Given this list of marker genes EMC4, STIP1, NDUFA4, ECT2, GTF2I, VAMP3, FIRRM, EPDR1, PSMA5, GPR160, SLC44A3, PSMG1, PBK, S100A10, UQCRFS1, CLNS1A, HSP90AB1, TPRKB, CCNDBP1, SEC61A1, YBX1, RACK1, CD46, GFM2, C1QBP, DCUN1D5, SLC39A6, CTNNAL1, PSMD8, FBXO10, MRPL42, MCTS1, MORN2, SEC23B, ARPC1A (NCBI Gene Id 10552), SCAMP3, TPX2, LSM2, ATF1, SKIC8, RNASEH2A, XRN2, UBE2T, SLC29A1, DCTN3, ADH5, IMPA2 (inositol monophosphatase 2), XRCC5, POLE2, PGD, STOML2, H2BC9, FKBP11, COPA, LAMTOR5, PSMC3, CCT4, FCER1G, PPP2R3C, CIAO2A, TPD52L1 (TPD52 like 1), MANF, TYROBP, HSPA13, MSH2, MRPS12, PRPS1, PSMD10, SPOPL, TM9SF2, HAT1, COPS3 (COP9 signalosome subunit 3), RFC3, PIGF, RFC4, GMNN (NCBI Gene Id 51053), SNX7, MRPL13, EBPL, HAUS1, H2AZ1, G3BP2, MAD2L2, RAN, SNRPD1, UBE2E3, NUP37, TP53RK, GLUD2, DPCD, ATIC (5-aminoimidazole-4-carboxamide ribonucleotide formyltransferase/IMP cyclohydrolase), SNHG29, PPIL1, SELENOT, HNRNPA0, RFC5, ME2, PDIA6, SLC25A5, NUDT21, CITED2, CAPZA2, CCT2, MRPS23, YAP1, MRPL39, NEU1, GJA1, MMGT1, TMEM50A, CNN3, RAD51AP1, DNAJA1, PSMA2 (proteasome 20S subunit alpha 2), RPS16, WDR83OS, DBI, FUCA2, CDK1, SMIM26, ABHD6, LYZ, STT3A, NFYC, ZNHIT3, CDK4, LYSET, ALG13, HIKESHI, MRPL44, APOO, POLE3, MED21, MAGED1, CAB39, ATP1A1, NUP205, TMX1, AQP11, PRMT6, WARS1, SEC11A, ACTR6, RNF141, RHOA, MAD2L1, RPS10P5, WDSUB1, RPL7A, RPA3, RAE1, TMBIM4 (NCBI Gene Id 51643), BAG2, ABCB10, CHCHD2, CENPH, TYMS, NONO, BAX, CDKN3, TAB2, CCNB2, PGK1, SNRPD2, DNAJB9, DPM1 (dolichyl-phosphate mannosyltransferase subunit 1, catalytic), FCGR3A, VBP1, OSTC, E2F5, MAPRE1, PCNA, HSPA8, C1GALT1C1, FARSA, SYPL1, FEN1 (flap structure-specific endonuclease 1), FUNDC1, ALDOA, WASHC5, RCN2, VDAC3, CMAS, ILF2, SNX2, GNAI1, TSPAN6, UXT, PRDX4, ATP6V0D1, METTL13, DAD1, ATG3, PRKAB1, here is a description of the gene set: from publication Chiang DY, Villanueva A, Hoshida Y, Peix J, Newell P, Minguez B, LeBlanc AC, Donovan DJ, Thung SN, Solé M, Tovar V, Alsinet C, Ramos AH, Barretina J, Roayaie S, Schwartz M, Waxman S, Bruix J, Mazzaferro V, Ligon AH, Najfeld V, Friedman SL, Sellers WR, Meyerson M, Llovet JM (PMID 18701503) Marker genes down-regulated in the 'unannotated' subclass of hepatocellular carcinoma (HCC) samples. Human Gene Set: CHIANG_LIVER_CANCER_SUBCLASS_UNANNOTATED_DN Hepatocellular carcinomas represent the third leading cause of cancer-related deaths worldwide. The vast majority of cases arise in the context of chronic liver injury due to hepatitis B virus or hepatitis C virus infection. To identify genetic mechanisms of hepatocarcinogenesis, we characterized copy number alterations and gene expression profiles from the same set of tumors associated with hepatitis C virus. Most tumors harbored 1q gain, 8q gain, or 8p loss, with occasional alterations in 13 additional chromosome arms. In addition to amplifications at 11q13 in 6 of 103 tumors, 4 tumors harbored focal gains at 6p21 incorporating vascular endothelial growth factor A (VEGFA). Fluorescence in situ hybridization on an independent validation set of 210 tumors found 6p21 high-level gains in 14 tumors, as well as 2 tumors with 6p21 amplifications. Strikingly, this locus overlapped with copy gains in 4 of 371 lung adenocarcinomas. Overexpression of VEGFA via 6p21 gain in hepatocellular carcinomas suggested a novel, non-cell-autonomous mechanism of oncogene activation. Hierarchical clustering of gene expression among 91 of these tumors identified five classes, including CTNNB1, proliferation, IFN-related, a novel class defined by polysomy of chromosome 7, and an unannotated class. These class labels were further supported by molecular data; mutations in CTNNB1 were enriched in the CTNNB1 class, whereas insulin-like growth factor I receptor and RPS6 phosphorylation were enriched in the proliferation class. The enrichment of signaling pathway alterations in gene expression classes provides insights on hepatocellular carcinoma pathogenesis. Furthermore, the prevalence of VEGFA high-level gains in multiple tumor types suggests indications for clinical trials of antiangiogenic therapies. studied in species Homo sapiens